Given this list of marker genes P2RX2, KCNK3 (potassium two pore domain channel subfamily K member 3), RPS6KA2, NAV2, ASIC2, CALCA, TACR1, TNNI3 (NCBI Gene Id 7137), MECP2, ADRA1A, AGTR2, MANF, SOD2, DRD2, ACE2, here is a description of the gene set: species: Homo sapiens Human Gene Set: GOBP_NERVOUS_SYSTEM_PROCESS_INVOLVED_IN_REGULATION_OF_SYSTEMIC_ARTERIAL_BLOOD_PRESSURE The regulation of blood pressure mediated by detection of stimuli and a neurological response.